Given this list of marker genes PSMA4, PSMD13, UBC, PSMC2, PSMC3, PSMB1, PSMD1, PSMA7, PSMD3, CD4, PSMB7, UBA52, PSMD14, PSMB6, PSMB4, SEM1, PSMC4, UBB, PSMA6, PSMA3, PSMA2, PSMC1, PSMD12, PSMC5, PSMB2, BTRC, vpu, PSMD7, PSMD2, PSMA5, PSMC6, SKP1, PSMD11, RPS27A, PSMB5, PSMD6, PSMA1, ADRM1, PSMB3, PSMD8, here is a description of the gene set: species: Homo sapiens part of: Host Interactions of HIV factors Reactome Pathway: Vpu mediated degradation of CD4 The HIV-1 Vpu protein promotes the degradation of the CD4 receptor by recruiting an SCF like ubiquitination complex that promotes CD4 degradation. Vpu links beta-TrCP to CD4 at the ER membrane through interactions with beta-TrCP and the cytoplasmic tail of CD4. The SKP1 component of the SCF complex is then recruited to the Vpu:beta-TrCP:CD4 promoting ubiquitination and subsequent proteasome-mediated degradation of CD4. Vpu has also been shown to also increases progeny virus secretion from infected cells. Although the precise role of Vpu in this process is not yet known, it may affect ion conductive membrane pore formation and/or interference with TASK-1, an acid-sensitive K+ channel that inhibits virion release in some cells (see references in Li et al., 2005).